Given this list of marker genes Glo1, Cxcr5, Foxi2, Copz1, Fosb, Nup98, Rab1b, Atg2a, Oprl1, Msl3l2, Cers2, Fkbp14, Suv39h2, Emp1, Pxn, Neurl1b (neuralized E3 ubiquitin protein ligase 1B), Hes3, Myo1c, Ajuba, Plxnc1, Gnl1, Dmrta2, Prdm13, Klra5, Dcaf11, Pax8 (paired box 8), Nyap1, Cacna1c (calcium channel, voltage-dependent, L type, alpha 1C subunit), Taf1d, Foxf2, Ddx6, Spink13, Nav1, Castor2, Zc2hc1c, Leap2, Syde2, Sirt6, Lasp1, Actn4, Vasp, Mcu, Etv4, Pdgfrb, Mef2c, Igf2, Fem1al, Hnrnpr, Slco3a1, Dock4, Abi1, Pla2g2f, Cacna1e, Agfg1, Cldn6, Magea5, Ccdc92b, Rasa4, Stmn4, Eda2r, Galnt17, Casq1, Xrcc2, Gfi1, Prkcg, Tmem135, Lrrc8d, Cdk19, Gal3st3, Fem1a, Sox12 (SRY (sex determining region Y)-box 12), Chd8, Inpp4b, Rela, Rnf2, Nr4a3, Pkhd1, Ddo, Gfra2, Bicd2, Phf8, Foxj1, Pgpep1, Hspb8, Rsad1, Vipr1 (vasoactive intestinal peptide receptor 1), Olah, Dedd, Mfng, Mecp2, Lingo2, H2-Q1, Zfp748, Tmed9, Syt3, Sinhcaf, Slc25a16, Or10ad1c, Socs7, Bcl2l11, Mrs2, Crispld2, Atl2, Ino80, Iqcg, Wnt1, Reep1, Clic5, 2310011J03Rik, Saa4, Fsd1l, Armc7, Spns2, Mdga2, Med29, Calcr, Slc23a2 (NCBI Gene Id 99086), Rad1, Atrn, Lin28a, Lmx1a, Rad51b, Gcc1, Niban2 (NCBI Gene Id 227737), Pank1, Pde1c, here is a description of the gene set: Mouse Gene Set: MIR_6356 species: Mus musculus Genes predicted to be targets of miRBase v22 microRNA mmu_miR_6356 in miRDB v6.0 with MirTarget v4 prediction scores > 80 (high confidence targets). from publication Chen Y, Wang X (PMID 31504780)